The following is a description of a gene set: The process resulting in the physical partitioning and separation of a neuroblast into daughter cells. A neuroblast is any cell that will divide and give rise to a neuron. Human Gene Set: GOBP_NEUROBLAST_DIVISION species: Homo sapiens, and this is the list of marker genes: FGF13, FGFR1, RAB10, ARHGEF2, AKNA, DCT, DOCK7, WNT3A, SOX5, LEF1, NUMBL, NUMB, TEAD3, FGFR2, ASPM